Given this list of marker genes DHCR24, DHCR7, PLPP6, SREBF1, LSS, ACAT2, SC5D, IDI1 (NCBI Gene Id 3422), PMVK, ARV1, FDFT1, MVK, SREBF2, HSD17B7, SQLE, MVD, MSMO1, FDPS, NSDHL, IDI2 (NCBI Gene Id 91734), CYP51A1, GGPS1, HMGCR, HMGCS1, LBR, EBP, TM7SF2, here is a description of the gene set: Cholesterol biosynthesis Human Gene Set: REACTOME_CHOLESTEROL_BIOSYNTHESIS species: Homo sapiens